The following is a description of a gene set: species: Homo sapiens Human Gene Set: GOBP_PYRIMIDINE_RIBONUCLEOSIDE_METABOLIC_PROCESS The chemical reactions and pathways involving any ribonucleoside, a nucleoside in which pyrimidine base is linked to a ribose (beta-D-ribofuranose) molecule., and this is the list of marker genes: APOBEC3G, CDADC1, APOBEC3C, CDA, AICDA, UPP1, DCTD, UPP2